Given this list of marker genes LMNA, SCN9A, RETREG1, COL3A1, KIF1A, WNK1, NOTCH2, ZMPSTE24, here is a description of the gene set: Foot acroosteolysis Human Gene Set: HP_FOOT_ACROOSTEOLYSIS species: Homo sapiens